Given this list of marker genes LALBA, TNNT1, KCNK5, PCTP, SPHK1, SERPINA12, ELL2, SLC15A3, FOXI1, ZNHIT2, AOC1, LTF, CXCR6, CLCNKA, LGALS7, EMB, CRY1, USP18, PSMC3IP, SURF1 (SURF1 cytochrome c oxidase assembly factor), CD96, B3GALNT1 (NCBI Gene Id 8706), ABI3BP, FANCL, PARP12 (poly(ADP-ribose) polymerase family member 12), TMED7, DERL3, AP1M1, ACOT7, ACTN2, LGALS3, STMP1, LARGE1, PBX3, GSPT2, ANXA5, NXF2, TSPAN3, CACNB3, ELK3, LCN2, RORC, ACADL, LYSMD2, PAPSS2, DNAJB6, WBP2, TMOD3, SAMD11, CRTAM, SERPINB6, HORMAD1, CHRNB2, FGFR4 (NCBI Gene Id 2264), STARD3NL, SDC3, TSPAN31, COX8A, ADAT2, OSTF1, S100A8, ZFPM2, RABGGTB, RAB3GAP2, PTGIR, PEX16, DBNL, DPH5, ISG20, ITPK1, C6, FABP5, NT5C3A, SEL1L, GLIPR2, KIAA1143, HCRT, HLF, ISG15, PDLIM4, COL4A2, HLA-A, GOLT1B, TULP4, TMED10, P4HB, RAP1B (RAP1B, member of RAS oncogene family), SERPINB1, CRIP1, S100A6 (NCBI Gene Id 6277), PRSS12, RIPPLY3, S100A4, TMEM176A, PSRC1 (proline and serine rich coiled-coil 1), CRBN, MBD2, ETV6, CLVS1, EFNA3, CEP19, SCIN, ADK, CDS2, TMEM30A, GNA15, PHETA2, CD80, MXRA8, TMEM203, PTPRA, CCN5, SERPINB9, TBCB, ANXA6 (NCBI Gene Id 309), MCFD2, DAPK2, HYI, GNG3, CD14, TRPV4 (transient receptor potential cation channel subfamily V member 4), SELENOM, UBXN2B, SMAD2, TMIGD1, STRC, IL1R1, ST6GALNAC1, PAQR7, ATP6V0B, LCORL, ADAMTS5, SLFN12, AKIRIN1, EGLN3, MRPS5, WNT8B, ANAPC11, ACLY, EMP1, RPL39L (NCBI Gene Id 116832), SPTSSA, ARL6IP5, TTC39C, GLIPR1, HAL, TSPYL4, RAB18, VOPP1, PLA2G2D, HLA-G, SH2D1B, GDPD3 (NCBI Gene Id 79153), ADA, LDAF1, CDKN2D, IL22, CMC2, SELPLG, PFN1, TMEM160, BASP1, CAMP, UAP1, LTBP2, SOAT1, TMEM176B, TNFRSF14, NR1D1, ATP6V0E2, DAZ2, PSPC1, SCPEP1, TMEM9B (NCBI Gene Id 56674), VMP1, COX18, ACYP2, PRDM1, CAP1, GRB7, MND1, ARL4C, PIWIL2, LGALS3BP, GFRA2 (GDNF family receptor alpha 2), NOCT, LTB4R, S100A9, APPL2, PAPPA, GIMAP7, RAB4A, TMOD4, BIK, DERL2, LAPTM4B, PRDX6, SYTL1, IPP, CAMK1, here is a description of the gene set: Triggering of B cell receptors (BCR) induces a massive synthesis of NFATc1 in splenic B cells. By inactivating the Nfatc1 gene and re-expressing NFATc1 we show that NFATc1 levels are critical for the survival of splenic B cells upon BCR stimulation. NFATc1 ablation led to decreased BCR-induced Ca++ flux and proliferation of splenic B cells, increased apoptosis and suppressed germinal centre formation and immunoglobulin class switch by T cell-independent antigens. By controlling IL-10 synthesis in B cells, NFATc1 supported the proliferation and IL-2 synthesis of T cells in vitro and appeared to contribute to the mild clinical course of Experimental Autoimmune Encephalomyelitis in mice bearing NFATc1-/- B cells. These data indicate NFATc1 as a key factor controlling B cell function. Genes up-regulated in B lymphocytes with NFATC1 knockout: control versus stimulated by anti-IgM for 3h. from publication Bhattacharyya S, Deb J, Patra AK, Thuy Pham DA, Chen W, Vaeth M, Berberich-Siebelt F, Klein-Hessling S, Lamperti ED, Reifenberg K, Jellusova J, Schweizer A, Nitschke L, Leich E, Rosenwald A, Brunner C, Engelmann S, Bommhardt U, Avots A, Müller MR, Kondo E, Serfling E (PMID 21464221) Human Gene Set: GSE21063_CTRL_VS_ANTI_IGM_STIM_BCELL_NFATC1_KO_3H_UP studied in species Homo sapiens